The following is a description of a gene set: studied in species Mus musculus Mouse Gene Set: GOMF_MONOCARBOXYLIC_ACID_TRANSMEMBRANE_TRANSPORTER_ACTIVITY Enables the transfer of monocarboxylic acids from one side of a membrane to the other. A monocarboxylic acid is an organic acid with one COOH group., and this is the list of marker genes: Slc6a6, Slc16a13, Slc16a14, Slc22a27, Slc10a5, Slco1a5, Slc16a3, Tspo2, Slc16a7, Slco1c1 (NCBI Gene Id 58807), Slc22a28, Slc2a1, Slc10a3, Nherf1, Slc10a6, Slc6a8, Slc22a26, Fabp2, Slc22a29, Slc16a5, Slc5a12, Ceacam1, Slc43a3, Slc10a7, Slc6a13, Abcg2, Slc5a8, Abcd2, Slco1a4, Slc22a13, Fabp4, Slc26a6, Abcc3, Mpc1, Slc51a, Slc27a5, Abcd4, Fabp3, Ceacam2, Abcb11, Fabp5, Slc27a2, Slc22a30, Slc10a4 (NCBI Gene Id 231290), Slc51b, Slc1a4, Slco2b1, Slc16a11, Slc27a6, Slc16a4, Slco1a7, Slc32a1, Slc5a6, Slco1a8, Slc10a4-ps, Abcc1, Slco1a6, Slc16a9 (solute carrier family 16 (monocarboxylic acid transporters), member 9), Mfsd2a, Slc16a8, Slc6a1, Slc16a6, Slc6a11, Slc27a4, Slc6a12, Slc22a19, Fabp1, Slc16a1, Abcc4, Slc27a1, Abcd1, Slco1a1, Cd36, Slc7a14, Abcd3, Slc10a1, Mpc2, Slc10a2, Slco1b2